Given this list of marker genes Gspt2, N6amt1, Trmt112, Apeh, here is a description of the gene set: Reactome Pathway: Eukaryotic Translation Termination This event has been computationally inferred from an event that has been demonstrated in another species.<p>The inference is based on the homology mapping from PANTHER. Briefly, reactions for which all involved PhysicalEntities (in input, output and catalyst) have a mapped orthologue/paralogue (for complexes at least 75% of components must have a mapping) are inferred to the other species. part of: Translation electronically inferred by orthology from the curated human pathway studied in species Mus musculus